Given this list of marker genes SLC16A2, CLN8, SLC38A3, CLTRN (collectrin, amino acid transport regulator), SLC6A7, SLC7A1 (solute carrier family 7 member 1), SLC6A20, TNF, SLC7A2, SLC7A8, ARL6IP5, ITGB1, SLC36A1, SLC38A5, GRM1, SLC3A2, SLC1A4, ARL6IP1, SLC6A6, SLC1A2, SLC36A4, SLC6A5, ATP1A2, SLC38A1, SLC38A2, SLC1A3, RGS2, NTSR1, SLC47A1, SLC1A6, SLC22A2, SEPTIN2, SLC7A11 (solute carrier family 7 member 11), SLC1A5, PER2, SLC38A4, SLC6A9, ACE2, SLC7A5, SLC1A1, SLC6A13, SLC22A4, SLC7A3, SLC43A2, SLC43A1, SLC17A8, PSEN1, TSPO2, KCNJ10, RGS4, GFAP, SLC6A14, here is a description of the gene set: species: Homo sapiens Human Gene Set: GOBP_AMINO_ACID_IMPORT_ACROSS_PLASMA_MEMBRANE The directed movement of an amino acid from outside of a cell, across the plasma membrane and into the cytosol.